Given this list of marker genes RSC1A1, CSK, VAMP4, RACK1, ATP2C1, ANXA13, CLN3, LYPLAL1, PKDCC, LYPLA1, ACSL3, CNST, here is a description of the gene set: Human Gene Set: GOBP_REGULATION_OF_GOLGI_TO_PLASMA_MEMBRANE_PROTEIN_TRANSPORT Any process that modulates the frequency, rate or extent of the transport of proteins from the Golgi to the plasma membrane. studied in species Homo sapiens